The following is a description of a gene set: Mouse Gene Set: chrXA6 studied in species Mus musculus, and this is the list of marker genes: Gm14718, Mmgt1, Fhl1 (four and a half LIM domains 1), Gm7073, Sox3, Gm14679, Ints6l, Rbmx, Gm6743, Zfp449, Gm14678, Snord61, Sms-ps, Gm14631, 1600025M17Rik, 4931400O07Rik, Gm26487, Fgf13, F9, Gm23258, Adgrg4, Mir504, Magec2, Arhgef6, Map7d3, Gm4988, Gm4909, Gm14661, Gm14633, Atp11c, Ldoc1, Gm5389, Brs3, Cdr1, Smim10l2a, Gm8111, Gm16411, Gm7327, Cd40lg, Gm14630, Gm8244 (predicted gene 8244), Gm14662, Zic3, Gm26312, Gm14647, Gm14656, Gm14660, Gm16436, Vgll1, Gm14663, Magea13, Gm7071, Gm14677, Rpl7l1-ps1, Gm14627, Tm9sf5, Gm14887, Gpr101 (NCBI Gene Id 245424), Gm5390, Gm8215, Ct45a, Gm6754, Gm8107, Gm8163, Hspa9-ps1, Mir505, Gm14665, Gm10477, Mir5116, Gm715, Gm2174, Gm14666, Mcf2, Gm14655, Gm2155, Tslrn1, Gm7076, Gm14890, Htatsf1, Slc9a6, Cdr1os, Gm773